The following is a description of a gene set: studied in species Mus musculus part of: Glucose metabolism Reactome Pathway: Glycolysis This event has been computationally inferred from an event that has been demonstrated in another species.<p>The inference is based on the homology mapping from PANTHER. Briefly, reactions for which all involved PhysicalEntities (in input, output and catalyst) have a mapped orthologue/paralogue (for complexes at least 75% of components must have a mapping) are inferred to the other species. electronically inferred by orthology from the curated human pathway, and this is the list of marker genes: Hk3 (NCBI Gene Id 212032), Gckr, Seh1l, Nup155, Nup58, Aldob, Eno4, Aaas, Nup205, Nup54, Pgam2, Pfkl, Nup85, Gnpda1, Pfkfb1, Rae1, Nup93 (nucleoporin 93), Tpi1, Nup42, Hk2 (NCBI Gene Id 15277), Pkm (NCBI Gene Id 18746), Nup210, Gapdhs, Ndc1, Eno3, Nup133, Hkdc1, Pgk2, Aldoa, Pgm2l1